Given this list of marker genes KLHL12, GSK3B, RET, BMPR1A, WNT10A, AKNA, OTUD5, HNRNPAB, TBX20, KITLG, TGFB1, SMAD4, MIR21, MIR144 (microRNA 144), DACT3, CDH2, SOX10, FOXC2, FGF10 (NCBI Gene Id 2255), EFNA1, FUZ (NCBI Gene Id 80199), ZNF750, TGFBR2, OSR1, SPRY2, HPN, EPHA3, CDC42, GATA3, VASN, GREM1, AMELX, SHH, NRTN, PITX2, SEMA4D, SEMA5B, EDNRB, POFUT2 (protein O-fucosyltransferase 2), NRP2, SEMA4B, PPP2CA, BMP5, PTEN, SEMA3B, TGFBR3L, GDNF, SEMA4A (semaphorin 4A), JAG1, GBX2, NKX2-1, EZH2, LOXL2, HDAC2, BCL9L, ROCK2, APLF, ALDH1A2, ELL3, TBX5, MARK1, MSX2, S100A4, IL1B, SNAI2, DAB2IP, SPRY1, HAND2, MAPK3, WNT11, KAT8, FRZB, DAB2, MIR573, BMP4 (bone morphogenetic protein 4), MSX1, HEYL, KBTBD8 (kelch repeat and BTB domain containing 8), MIR326, BAMBI, MIR372, FOLR1, EXT1, LOXL3, LDLRAD4, MIR519D, FGFR2, ZEB2, CFL1, MIR18A, MDK, TWIST1, SP6, RANBP3L, WNT8A, FAM83D, MAD2L2, ZNF703, SMAD3, NOLC1, IL17RD, STAT1, LAMA5, POLR1B, FN1, FBXO11, SOX9, LIMS1, TNXB, SFRP1, HIF1A, PDCD4, SEMA3G, NOTCH4, SERPINB3, TBX3, SEMA3E, TIAM1, QKI, WWTR1, MIR342, EPB41L5, HMGA2, ACVRL1, RDH10, PDPN, LRG1, FOXA1 (NCBI Gene Id 3169), SPRED3, FGF19, FOXA2, OVOL2, ALX1, EOMES, TGFBR1, WNT4, SIX1, HES1, SEMA5A, MCRIP1, RPS7, PPP3R1, ERBB4, SPRED2, ADIPOR1, TMEM100, SFRP2, SEMA4F, CYP26C1, EMP2, EDN1, SEMA7A, ADAM8, RBPJ, WNT16, NRG1, RFLNB, NOG, DSG2, OLFM1, LEF1, TGFB3, PDCD6, NOTCH1, SEMA4G, PHOX2B (paired like homeobox 2B), RGCC, IGF1 (NCBI Gene Id 3479), HEY1, ADAM15, MIR590, SLC39A10, SEMA6B, MIR149, SMO, PEF1, ZFP64, SEMA3D, GATA5, RADIL, HEY2, ENG, IL6, SNAI1, VEGFA, GSC (NCBI Gene Id 2927), CRB2, MIR302B, TGFB2, PTK2, MTOR, MIR379, TAPT1, MIR29B1 (NCBI Gene Id 407024), TRIM28, MIR204, TGFBR3, BMP7, HTR2B, TCF21, CUL7, MIR19B1, SPRED1, HAS2, SEMA6C, ROCK1, TBX1, FGF8, FERMT2, TCF7L2, EDNRA, SEMA6D, PHACTR4, PAX2, DLG5, SPSB3, FOXF2, ACVR1, SEMA4C, EPHA4, EFNB1, CORO1C, MEF2C, COL1A1 (NCBI Gene Id 4970), CTNNB1, SIX2, BMP2, MIR145, TGFB1I1, MIR202, MIR222, WNT5A (Wnt family member 5A), BCL2 (NCBI Gene Id 596), MIR130A, DDX17, GCNT2, FGFR1, RTN4, DDX5, SLC39A6, NRP1, SMAD2, SDHAF2, ISL1, FBXL17, NCAM1, AGT, TASOR, SEMA3F, HGF, MIR19A, TCOF1 (NCBI Gene Id 6949), TRIM62, WNT2, MIR142, SEMA3A, LRP6, KDM1A, SDCBP, EDN3, SMAD7, SOX8, CITED2, GLIPR2, MIR221, SEMA3C, SEMA6A, USF3, FOXC1, ARB2A, AMER1, AXIN2, MAPK1, here is a description of the gene set: Human Gene Set: GOBP_MESENCHYMAL_CELL_DIFFERENTIATION studied in species Homo sapiens The process in which a relatively unspecialized cell acquires specialized features of a mesenchymal cell. A mesenchymal cell is a loosely associated cell that is part of the connective tissue in an organism. Mesenchymal cells give rise to more mature connective tissue cell types.